Given this list of marker genes Nudt5, Nt5c1a, Adprm, Gda, Pnp, Nt5c, Nudt16, Nt5c1b, Xdh, Pnp2, Nudt15 (NCBI Gene Id 214254), Nudt18, Nudt9 (nudix hydrolase 9), Nt5c2, Nudt1, here is a description of the gene set: part of: Nucleotide catabolism This event has been computationally inferred from an event that has been demonstrated in another species.<p>The inference is based on the homology mapping from PANTHER. Briefly, reactions for which all involved PhysicalEntities (in input, output and catalyst) have a mapped orthologue/paralogue (for complexes at least 75% of components must have a mapping) are inferred to the other species. electronically inferred by orthology from the curated human pathway studied in species Mus musculus Reactome Pathway: Purine catabolism